The following is a description of a gene set: species: Homo sapiens Any process that modulates the frequency, rate or extent of hyaluronan biosynthetic process. Human Gene Set: GOBP_REGULATION_OF_HYALURONAN_BIOSYNTHETIC_PROCESS, and this is the list of marker genes: EGF (NCBI Gene Id 1950), NFKB1, TGFB1, PDGFB, SMPD3, HAS2, CLTC, AP2A1 (NCBI Gene Id 92649)